Given this list of marker genes POLD3, ECT2, TNFAIP8, CTAGE1, RPS3, CLEC2D, SHQ1, SENP7, CASP8AP2, STK26, PDCD6IP, STK24, AGL, SGPL1, DR1, GGA2, TAF7, SEPTIN7, CDKN2D, SP110, ARHGEF18, HLA-DPB1 (NCBI Gene Id 3115), TNIK, REL, GARRE1, SMAD4, TDP2, NPM1, CDC7, STAT6, NRIP1, CEP135, RIPOR2, KYNU, SNX10, ARPC5, PMS2P2, SNAP23 (synaptosome associated protein 23), ATP6V1B2, RPL11 (ribosomal protein L11), POLDIP3, SORL1 (NCBI Gene Id 6653), RPL17, USP25, XPO1, PAX5, PRKCB, YPEL1, MYL12A, LYST, TARBP1, IKBKB, CD72, SYPL1, DDX5, STX7, VAPB, SPRY1, FGR, LY86 (NCBI Gene Id 9450), RPL31, NUP62, ELOVL5, RPS7, CD79B, NUP43, PANK3, CCT5, RPL27, CDC40, PHTF2, SRSF7, DAAM1, PAWR, RASGRP2, MYLIP, PIKFYVE, ZNF273, PAK2, ANXA10, CD1C, SRSF5, PIGG (phosphatidylinositol glycan anchor biosynthesis class G (EMM blood group)), BLCAP, ABHD18, CLMN, HLA-DMB, DMXL1, DNAJC16, SLC2A1, MAPRE2 (microtubule associated protein RP/EB family member 2), BAZ1A, HCP5, INPP5D, DAZAP2, TTC31, ZNF529, SWAP70, MAT2B, ATF7IP, RBM5, DYRK2, CLASRP, PDE8B, WDR55, SLC25A24, FRY, STAT5B, CR2, API5, CORO1A, TMEM131L, AIM2, TRMT13, RPS29 (ribosomal protein S29), METTL4, TIPRL, LTB, MKNK1, GIT2, PPP1R16B, NOTCH2, VAV3, NSUN5P2, KAT6A, COL6A3, SNN, TRAC, CDC73, SEPTIN9, CAT, ZBTB25, FBXO38, MAPK1, RUBCNL, GABBR1, FYN, PTMA, KCTD7 (NCBI Gene Id 154881), ENTPD1, FASTKD2, TIA1, ARFIP1, DENND3, BIN1, PVRIG, RFX5, PPID, POGZ, DGCR8, PDCD10, MCUB, RNF111, CAPG, UVRAG, RBL2, NACA, HUWE1, PIK3CD, GPRASP1, MYL12B, MARCHF1, PHC1, ZCCHC2, AKAP11 (NCBI Gene Id 79988), P2RX5, SF3A2 (NCBI Gene Id 8175), ZNF480 (zinc finger protein 480), PKIG, TRIM13, HLA-DMA, ARHGAP45, TSC22D1, CNOT8, AGPS, PRKACB, TBC1D4, PMP22, QRSL1, DPP8, VAMP2, ZDHHC6, PMS2P3, LAPTM5, PPP1R12A, STK38, ARPC4, PUM2, CD22, POLR2A, IFNA17, RPS28, SMCHD1, GCA, QKI, PNRC2, CNDP2, MORC3, ATP6V1H, RAP1GDS1, here is a description of the gene set: Human Gene Set: GSE22886_IGG_IGA_MEMORY_BCELL_VS_BM_PLASMA_CELL_UP species: Homo sapiens Genes up-regulated in comparison of memory IgG IgA B cells versus plasma cells from bone marrow and blood. Immune cell-specific expression is one indication of the importance of a gene's role in the immune response. In order to identify such patterns, we set out to broadly profile gene expression in a variety of immune cells. from publication Abbas AR, Baldwin D, Ma Y, Ouyang W, Gurney A, Martin F, Fong S, van Lookeren Campagne M, Godowski P, Williams PM, Chan AC, Clark HF (PMID 15789058)